The following is a description of a gene set: Any process that stops, prevents, or reduces the frequency, rate or extent of oligodendrocyte differentiation. Mouse Gene Set: GOBP_NEGATIVE_REGULATION_OF_OLIGODENDROCYTE_DIFFERENTIATION studied in species Mus musculus, and this is the list of marker genes: Id2, Sirt2, Lingo1, Nkx6-2, Tmem98, Dlx1, Hes1, Nf1, Notch1, Bmp4, Dusp10, Daam2, Hes5, Dlx2, Id4, Drd3, Ctnnb1 (catenin beta 1), Nkx6-1